Given this list of marker genes SLC49A4, IL6ST, EPHX1, RALGPS2, SLC14A1, PRMT3, IL7R (NCBI Gene Id 3575), LYRM7, NKD2, SELL, DAPL1 (death associated protein like 1), AFP, AP1AR, TET1, RIC8B, SLC12A7, ID3, ITGAE, CYLD, RASGRP1, EXOSC10, ARHGAP35, DNTT, N4BP2, LRRC1, UTP25, DPH5, TANC1, MAP3K3, FAM78A, LRIG1, SBSN, RPL19, BACH2, MDN1, GAR1, EVL, TREML2, RAMP1, RAB6B, PIK3IP1, PLEKHA1, CARD6, TDRKH, GRAP2, TRAT1, IGFBP4, CARNS1, WLS (Wnt ligand secretion mediator), TTC28, ZNRF1, ARHGAP29, RNF167, FOXP1, SH3BP5, TOM1L2 (NCBI Gene Id 246315), BEND5, RGS10, SLC25A27, AGK, CUX1, EML5 (EMAP like 5), POU2F1, NSG2, MGST2, SIDT1 (NCBI Gene Id 54847), SCMH1, RAPGEF6, ABTB3, EPC1, CCR7, RUFY2, SCML4, AMPD1, ADGRG5, ABCA1, RAB3IP, LDLRAP1, RAPGEF4, LRP6, SLC16A5, USP24, SESN1, ANGPTL1, RFX1 (NCBI Gene Id 5989), PARP6, RNF122, METTL8 (methyltransferase 8, tRNA N3-cytidine), LRCH3, KIZ, SH3PXD2A, MDC1, IGF1R, HSPBAP1 (HSPB1 associated protein 1), IKBKE, POLR1G, SLC11A2, ADCY6, APPL2, USP28, FOXO1, MTSS1, CRIPTO, SPACA1, POLR1A (RNA polymerase I subunit A), IL27RA, TGFBR3, RPS29, MGRN1, TNIK, DZIP1, ACTN1, LDHB, MIR20A, TLR1, TIMP2 (NCBI Gene Id 7077), IPCEF1, S1PR1 (sphingosine-1-phosphate receptor 1), ST8SIA1, ZMYM2, MYC, POLI, GPATCH4, PRSS12 (serine protease 12), ABCG1, DCAF6, DDC, PATJ, CREBL2, IZUMO1R, SELE, ST6GAL1, NEDD4L, ZBTB20, CHST15, ZBTB4, LEF1, IFT80, ZNF318, PDK1, SSH2, TTC3, TCF7, BCKDHB, SSBP2, ICE2, EYA2, PALS1 (NCBI Gene Id 64398), RNF144A, IFNGR2, INSR, ELMO3, NPFF, GRIA3, FOXK1, CAND1, IGFLR1, CNGA1, KDM5B, XKRX, BCOR, ZEB1, here is a description of the gene set: Genes up-regulated in hematopoietic stem cells versus megakaryo-erythrocyte progenitors. from publication Ng SY, Yoshida T, Zhang J, Georgopoulos K (PMID 19345118) Human Gene Set: GSE15330_HSC_VS_MEGAKARYOCYTE_ERYTHROID_PROGENITOR_UP species: Homo sapiens Regulation of lineage potential and transcriptional priming by Ikaros. New insight is provided into a bivalent regulation of lineage priming in the HSC and its lympho-myeloid restricted progeny the LMPP by the lymphoid lineage-determining factor Ikaros Whereas Ikaros is responsible for the activation of a cascade of lymphoid expression programs and for the establishment of lymphoid potential from the HSC to the LMPP it is also responsible for the repression of stem cell and erythroid genetic programs that are incompatible with further lineage restrictions emanating from the LMPP